Given this list of marker genes LY96, TPP1, GPRIN3, NPL, RNASE6, P2RY12, IL13RA1, VAV1, SGK1, WIPF1, RBM47, CD53, ZFP36L2, RNF125, IL16, IL4R, BMP2K, CPVL, LYN, OLFML3, C17orf67, SLCO2B1, ADPGK, STXBP2, NR3C1, AXL (AXL receptor tyrosine kinase), DAB2, BCAP29, EFHD2, MS4A7 (NCBI Gene Id 64230), IGFBP3, SYNGR2, CD36, RGS1, CD74, C3AR1, NR4A2, PALD1, KCTD12, HSPD1, RASSF4, ACSL5, CCRL2, CTSC, CD83, CREM, FCGR1A, MPP1, DRAM2, SYK (NCBI Gene Id 6850), LTA, ITGB2, MAP3K8, CSF1, LPAR6, INTS6L, KCNK6, PGGHG, FKBP4, LPL (lipoprotein lipase), MLKL, APOE, SPI1, FHL3, VSIG4, STAT1, CTSH, DERL3, TFEC, TRPV2 (NCBI Gene Id 51393), NEAT1, ITPR2, ELOVL1, CYTIP, TASL, PAG1, CCL3, PLAUR, FKBP15, LGMN, MS4A4A, SOD2, BRI3, MYADM, CD44 (CD44 molecule (IN blood group)), APBB1IP, NCKAP1L, TLR7, UBA7, PPT1, SNHG12, SLC1A5, FOLR2, NAGA, TMEM119, DPF3, RREB1, GPX1, MRC1, P2RY13, CYBA, LITAF, CD37, CYBB, DENND3, CTSL, SIRPA, HBG2, HSPH1, VAMP8, GPR183, PCED1B-AS1, OLR1, SLC7A11, OAS1, CCR1, FKBP5, PNRC1, NKX2-2, GM2A, STAB1, CD84, RILPL2, CDH17, SOX14, SLC25A19, LIPA, FPR1, SCARB1, GSN, TLN1, EDEM1, RIN2, CORO1B, ANXA5, GAS6, KLF3, MANBA, TMT1A, SKAP2, NCF2, KRT17, HSPA6, NEU4, FGL2, PMAIP1, RAB13, CSRNP1, ITSN2 (intersectin 2), TOR3A, KIF14, CYTH4, TIAM1, CARD11, HBA2, TXNIP, ZC3HAV1, PIK3IP1, TMBIM1, CASP1 (NCBI Gene Id 834), PIK3CG, NLRP3, ETS2, ZFP36L1, NPC2, IL17RA, HCLS1, FGL1, TRIM22, JAK3, HS3ST1, UCP2, RNF213, SELPLG, NRG2, TGFBR2, MAFB, IKBKE, RGS19, CTDSP1, LAIR1, FOSB, HPGDS, MFNG, B2M, OPRK1, PTPRC, HSPA7, NCF4, TPT1, ZNF48, CD86, CARD9, PTPN6, TYMP (thymidine phosphorylase), BIN2, ABI3, TENT5A, SORL1, TRIM38, OTUD1, IL1R1, ADAT2, IRF1, PDPN, PPP1R15A, ANKRD44, SH2B3, ADCY7, CDKN1A, PTGER4, TMEM144, SPP1, ERF, CYFIP1, SLC25A39 (solute carrier family 25 member 39), RUNX1, TAL1, APOC2, CNPY3, HERPUD1, BHLHE41, SAMSN1, HSPB1, MARCHF1, MKNK1, KBTBD8, TNFAIP3, ITPRIPL2, MFSD12 (major facilitator superfamily domain containing 12), IER2, MAFF, ALOX5AP, RASGEF1B, SLA, TBC1D12, GMFG, TNFSF9, SYT6, CD4, LRRC8C, ZFP36, PTK2B, NR4A1, RHBDF2, CREG1, OGFRL1, HSD17B14 (NCBI Gene Id 51171), CEBPD, GNB4, SUCLG2, NAV3, MYLIP, TNFRSF1A, MPEG1, DRAM1, HCST, YPEL2, FABP3, LYST, GYPC, SNX1, IL18, HHEX, IL7R, BIN1, TNFRSF1B, PLVAP, NIBAN1, ICA1, GPR65, HAUS4, B3GNT5 (NCBI Gene Id 84002), EGR3, CAPG, TAMALIN, ATF3, DOK2, ARHGAP45, ACSF2, CXCL8, PLCG2, TMEM19, XAF1, ERMAP, PARP14, BCL3, ZNF217, DOCK1, ELL2, MFSD1, MNDA (myeloid cell nuclear differentiation antigen), TMEM63A, BTK, LRRK2, IL6R, NFKBIA, ANXA11, LAPTM5, RCSD1, APOC1, SNX18, CSF3R, CEBPA, POLD4, COLGALT1, C12orf75, GLRX, FERMT3, DEPTOR, MAP3K5, ENTPD1, ST6GAL1, NFKBIZ, SIGLEC1, SAMHD1, GIMAP5, SQSTM1, ICAM1, SAT1, STING1, ARHGAP25, SLC6A3, C1QC (complement C1q C chain), TLR1, HMOX1, SCAMP2 (NCBI Gene Id 10066), IER5, P3H2, INPP5D, CASP9, HBG1, WASF2, TYROBP, NINJ1, APOBEC3D, MMRN1, AFF1, ZC3H12A, REL, ANXA4, MICOS10-NBL1, STK17B, SCPEP1, IL27RA, EGR2, IKZF1, BCL2A1, LY86, RAP2C, GLIPR1, STX11, ABCG1, CSF1R, SFMBT2, SRGN, BLVRB, CCDC175, RASSF3, MIR221 (microRNA 221), CD68, NPC1, EVI2B, LPCAT2, RUNX3 (NCBI Gene Id 864), CTSS, ASAH1, CD274, SLC4A4, TAGAP, KCNE3 (potassium voltage-gated channel subfamily E regulatory subunit 3), MCTP1, GADD45B, GPR137B, TOR4A, USP36, APOBEC3C, GPNMB, PYGL, DOCK4, KCNK3, HTRA1, SLC4A1, PLEK, IL1B, HBA1, WNT7B, ADORA3, PLSCR1, IGSF6, NFATC2, PPP3R1, LILRA2, MYO1F, ADCK2, IL6ST, CHCHD1, MAP2K3, ITGAV, ANOS1, GATM, SNORD114-1, ZFAND2A, ACY3, HAVCR2, IPCEF1, FLI1, MGST2, ARHGAP4, BIRC3, RYR2, ADAM28 (NCBI Gene Id 27337), FOXN3, STAT6, SCARNA9, MAF, UBC, FCGRT, PRKCA, CCL4, LILRB4 (leukocyte immunoglobulin like receptor B4), IRF8, FGD2, CLEC7A, GPR34, POU2F2, RAB3IL1, PIEZO1, TMEM35B, DPP7, BLNK, ITM2B, A2M, PTPRE, PROCR, RHOG, KRT5, FCGR1BP, EXOSC5, SERPINF1, MBP, PTPN18, LTBR, GNGT2, CD5L, PRDM1, FCGR3A, FCGR2A, TM6SF1, FAR2, PLA2G15, PARP9, DHRS3, HPSE, PDK4, GNG7, PPFIA4, FCER1G, DNAJB4, PYCARD, EGR1 (NCBI Gene Id 1958), CD163, C3, LIMS1, ATP8B4, ULBP1, TLR4, NAIP, ADAP2, FTL, GIMAP4, PCDH12, GAB3, TICAM1, RAB32, AP1B1, NFATC1, CX3CR1, SLC11A2, AGR2, MALT1, ALOX5, CXCL2, MERTK, RASAL3, ARPC1B, ARHGDIB, RPS6KA4, DNAJA4, C1QB, DUSP2, KRT14 (NCBI Gene Id 387571), DENND4A, CMKLR1, DUSP1, DNAJB1, TNFRSF11B, DHRS9, PLAU, HRH1, APOBR, CCDC17, PTGS2 (prostaglandin-endoperoxide synthase 2), NEK6, PITHD1, IRAK2, STAT5A, ADAMTSL4-AS1, IGF1, CASP4, CTSD, ARHGEF6, BDNF, B4GALT1, CCL2, SLC37A2, MOB3C, ELF1, PLCB2, PLD4 (NCBI Gene Id 414770), CD69, DOCK8, TREM2, PCDHGC3, PAQR8, FOXO3, LCP1, ARRB2, SLC15A3, ARRDC2 (arrestin domain containing 2), PPIF, TESC, OSTF1, IFNGR1, GRN, LPAR5, CDK7 (cyclin dependent kinase 7), CRYBB1, CTSB (cathepsin B, NCBI Gene Id 3896), ARHGAP26, C1QA, RIPK3, NUP37, EVI2A, SIGLEC14, RGL1, PLXDC2, JUNB, ANO1, INPPL1, SPINT2, SLC7A7 (solute carrier family 7 member 7), C1orf54, P2RX4, CAPZB, FYB1, TMC8, LHFPL2, PTAFR, GAL3ST4, STOM, SASH3, KLF2, CD14, SEPTIN6, IFI16, CPED1, CD48, BAG3, PARVG (parvin gamma), KIAA1755, LAT2, SCIN, RNASET2, KCNK13, MEF2C, SLC9A9, here is a description of the gene set: from publication La Manno G, Gyllborg D, Codeluppi S, Nishimura K, Salto C, Zeisel A, Borm LE, Stott SRW, Toledo EM, Villaescusa JC, Lönnerberg P, Ryge J, Barker RA, Arenas E, Linnarsson S (PMID 27716510) species: Homo sapiens Cell types are named using anatomical and functional mnemonics prefixed by 'm' or'h' to indicate mouse and human respectively: OMTN, oculomotor and trochlear nucleus; Sert, serotonergic; NbM, medial neuroblast; NbDA, neuroblast dopaminergic; DA0-2, dopaminergic neurons; RN, red nucleus; Gaba1-2, GABAergic neurons; mNbL1-2, lateral neuroblasts; NbML1-5, mediolateral neuroblasts; NProg, neuronal progenitor; Prog, progenitor medial floorplate (FPM), lateral floorplate (FPL), midline (M), basal plate (BP); Rgl1-3, radial glia-like cells; Mgl, microglia; Endo, endothelial cells; Peric, pericytes; Epend, ependymal; OPC, oligodendrocyte precursor cells. Human Gene Set: MANNO_MIDBRAIN_NEUROTYPES_HMGL